Given this list of marker genes SLBP, EIF2S3B, EIF4A1, RPL13A, MCTS2, EIF2S2, EIF3D, NCK1, EIF3CL, EIF2S3, IMPACT, EIF3G, EIF3A, EIF2B2, MTOR, NCBP2, EIF3B, EIF4G1 (eukaryotic translation initiation factor 4 gamma 1), EIF4B, DHX29, EIF3F, EIF3I (eukaryotic translation initiation factor 3 subunit I), EIF2B5, MIF4GD, EIF3H, EIF2B3, PKP1, NCBP1, EIF3C, EIF3J, RBM4, SH3BGRL, EIF3E, EIF4A2, EIF5, EIF3L, AKT2, YTHDF2, HHEX, METTL3, DENR, EIF2B1, EIF2D, MCTS1, EIF3K, EIF4H, EIF3M, EIF2B4, here is a description of the gene set: studied in species Homo sapiens The process preceding formation of the peptide bond between the first two amino acids of a protein in the cytoplasm. This includes the formation of a complex of the ribosome, mRNA or circRNA, and an initiation complex that contains the first aminoacyl-tRNA. Human Gene Set: GOBP_CYTOPLASMIC_TRANSLATIONAL_INITIATION